Given this list of marker genes TNFSF15, BEST1, MICALL1, AKAP13, DHX32, CDC14B, LACTB, STRIP2, TRMT10B (NCBI Gene Id 158234), CD207, PUS10, KAT5, SELENOW, LENG8, TTC39B, MSS51 (NCBI Gene Id 118490), LRRC9, FBXO47, NUDT13, PNPLA3, NEUROG2, WRN, RPS15A, MUSTN1, GUCY1A2, CHIC2, DISP2, CCR8, BMS1, LRRC49, NFAT5, KLF7, GIGYF1, ACOT6, SMC5, USP35, RNF182, PNMA2, UBE3C, IL13RA2, RANBP9, XRRA1, SNRK, FOCAD (focadhesin), YEATS4, UBE2V2, TRPC1, FAM156A, DIDO1, EWSR1 (NCBI Gene Id 2130), ARHGEF1, PIP4K2B, KRT24, DDX24, SMURF1, CDH12, RNF168, CHD2, VPS51, BHLHA15, GMNN, CCDC61, RXFP4, TOP2B, LGR4, PROX2, NCK2, PGLYRP3, CYSLTR2, PTPN20, CSNK2A2IP, ACTR6, GGH, CHRNE, MACROH2A2, TMF1 (NCBI Gene Id 7110), IL15RA, SLC37A2, OSBPL6, TAOK1, CTSW, RAB1A, EFCAB7, ZMAT4, MIER1, DBR1, SDHA, DPPA2, RB1CC1, MTA3, PGAM2, NAA15, MIGA1, ZMYM4, LHFPL3, SGMS1, FBXW7, TRPM4, GRP, PCDHB2, GPR151, PDS5B, CKAP5, HSF2, CAPRIN2, FMNL3, MYOZ1 (myozenin 1), IFT81, TADA2A (NCBI Gene Id 96291), ST8SIA5, PGBD1, CABP4, RTN4, SLC4A7, ANKRD13D, LPAR4, NKTR, SLK, RGS22, KIF13B, PPIH, DEF8, RPP14, HELB (DNA helicase B), SCUBE2, CDADC1, SDCCAG8 (NCBI Gene Id 10806), SMCP, DAPP1, CTSK, ITPR2, SOCS6, CTSO, CCDC159, SGTB, KCNE3, SUCLA2, here is a description of the gene set: Genes down-regulated in of bone marrow progenitors: 4- versus 8-day cultures. Human Gene Set: GSE12003_4D_VS_8D_CULTURE_BM_PROGENITOR_DN from publication Baek D, Villén J, Shin C, Camargo FD, Gygi SP, Bartel DP (PMID 18668037) studied in species Homo sapiens This array analysis is to study developmental time course of the regulation of target messages’ expression during culture of murine neutrophils versus miR-223 null neutrophils. Culture media was SILAC-IMDM for MS analysis.